The following is a description of a gene set: studied in species Homo sapiens Gene expression analysis of freshly isolated CD14+ human monocytes and monocytes cultured in the presence or absence of interferon (IFN) -gamma for 24 h and then stimulated with Pam3Cys, a Toll-like receptor (TLR) 2 ligand, for 6 h. Results provide insight into mechanisms by which IFN-gamma reprograms early macrophage differentiation and subsequent response to TLR ligands. Human Gene Set: GSE11864_UNTREATED_VS_CSF1_IFNG_IN_MAC_UP Genes up-regulated in comparison of untreated macrophages versus those cultured with M-CSF and IFNG. from publication Hu X, Chung AY, Wu I, Foldi J, Chen J, Ji JD, Tateya T, Kang YJ, Han J, Gessler M, Kageyama R, Ivashkiv LB (PMID 18976936), and this is the list of marker genes: EPRS1, PROX1-AS1, TPT1P8, ELF2, CLASRP, ZNF296, H2BC11, ZNF669, VIPR1, SLC25A34, HMGXB4, RPS9, DUSP7, ZBTB43, MPRIP, MYH9, ATF6B, ERGIC3, JOSD1, BICRA, TENT5C (terminal nucleotidyltransferase 5C), DLGAP4, RPL12, GZF1, KPTN, PCIF1, HNRNPDL, KIF9, SH3BGRL, REPS2, RPL23, KCTD7, SESN2, C11orf21, ADRB1, SLC25A36, MAFF, TUG1, SVIL, ZDHHC9, DDX3Y, SLC46A2, SMARCE1, FRY-AS1, RPS6, SERTAD2, JDP2 (NCBI Gene Id 122953), ZDHHC7, ELOVL5, PDCD6P1, DPH5 (diphthamide biosynthesis 5), ALPK2, NARF, FBXW4, ZNF521, NET1, WDR45B, UVSSA, GOLM2, C1orf52, FLT3, SSH2, SCGB2A2, CNIH1, TBRG1 (NCBI Gene Id 84897), TAF9B, TRIM11 (tripartite motif containing 11), DBP, CRYL1, EPB41L4A-AS1, NT5DC1, DNTTIP2, ZC3H7A, IKZF5, SH2B2, XRCC5, LGALS8, BST1, RPL22, SAT2, HNRNPA1L2, NFYC-AS1, PFKFB4, IRAK4, HHEX, AOAH, IDH3G, EVI2B, NCK2, TCEA1, GLTP, SIRPD, UBL3, CPNE2, NAA80, FGR, PTPN18, WASF2, RUNX3, SLC5A4, AHR, TRPM4, TLE3, CNPPD1, ITSN1, PHF10, ORMDL1, ALDH2, SVBP, P2RX1, TTLL5, RAP1A, GS1-279B7.1, GNB1, NTF3, UBXN11, MRPS30, GID8, GPS1, RARA, TSPYL4, MIR646HG, FAAP20, TIMM9, LRCH4, LYPLA1, RTRAF, ZXDC, IMPDH1, POFUT2, ZDHHC3, PCDHGA8, CACNA2D4, CHRAC1, NHERF1, IL12A, SMYD3, MARCHF8 (membrane associated ring-CH-type finger 8), BIN3, LIN7A, RPL6, TEX22 (testis expressed 22), TAFAZZIN, TRAK1, PURB, MEF2D, SMAD7, RPS11, TMEM170B, MRAP2, LMO2, ZNF281, STK19, SPTLC2, ELK3, LINC00877, CCDC88C, RIPK2, ZFTA, TMEM63C, FAM161B, RHBDD2, RPL41, ZNF598, TCF7, PLB1, RAP1B, VPS26B, MICAL2, ITPKB, CD79B, UTY, PDCD6IP, RPL24, YPEL3, GAB2, ZNF160, AP2M1, SLAIN1 (NCBI Gene Id 122060), NRIP3, PHYKPL, PSPC1, SLC12A9, SLC41A3, CHMP1B, PTK2, SGSM2, VPS13A, MAPKAPK3, CDK2AP1, FAM43A, RNF135, RNF139, FMO5, PET117